The following is a description of a gene set: species: Homo sapiens The chemical reactions and pathways involving acyl-CoA, any derivative of coenzyme A in which the sulfhydryl group is in thiolester linkage with an acyl group. Human Gene Set: GOBP_ACYL_COA_METABOLIC_PROCESS, and this is the list of marker genes: NUDT7, ACLY, ACOT2, ACOT12, HSD17B12 (NCBI Gene Id 51144), PDK3, MCEE, HMGCS2, TPK1, ACSL1, ACSL5, SUCLG2, ELOVL6, ACSM2A, ACSBG2, NUDT19, PDHA2, ACSF2, SNCA, PMVK, ACSS2, TECR, DLD, ACAT1 (acetyl-CoA acetyltransferase 1), PDK1, ACSM5, OXSM, MMUT, THEM5, PDHX, ACACB, ACOT8, AASS, TDO2, PPT1, GLYAT, GPAM, OGDH, FAR1, ACSM1, ACSL4, AADAT, ELOVL5, SUCLG1, MVK, BCKDK, HMGCS1, HACD2, PDHB, ELOVL3, GCDH, ACSM2B, PDK2, PPCS, NUDT8, HSD17B4, ACOT4, ACSF3, HTD2, PPT2, ACSS1, MLYCD, FASN, ENSG00000293349, PGK1, FAR2, ELOVL7 (ELOVL fatty acid elongase 7), ABCD1, ACSL6, PDK4, ELOVL4, ELOVL2, BAAT, HACD1, PDHA1, ACSM4, ACOT9, SUCLA2, PIPOX, CBR4, FITM2, ACSM3, ACSBG1, MPC2, SLC27A2, MVD, ACOT6, ACOT7, DGAT2 (NCBI Gene Id 84649), DGAT1, ACOT1, DLST, GPAT4, ACSM6, ACSL3, ACACA, ACOT11, ELOVL1, DIP2A, DLAT